The following is a description of a gene set: Pathway Definition from KEGG: DA -> DRD1 -> GNAS -> ADCY5 -> cAMP -> PKA -> CREB Human Gene Set: KEGG_MEDICUS_REFERENCE_DRD1_GNAS_AC_PKA_SIGNALING_PATHWAY species: Homo sapiens DRD1-GNAS-AC-PKA signaling pathway. Pathway ID: N00410. Pathway type: Reference. Pathway class: nt06167 Human cytomegalovirus (HCMV)., and this is the list of marker genes: GNAS, CREB3, PRKACB, ADCY5, ATF2, PRKACG, CREB3L4, ATF4, CREB3L3, DRD1, CREB5, ATF6B, CREB3L1, PRKACA, CREB3L2, CREB1